Given this list of marker genes GBP1, S1PR2, P2RY1, NCOA7, IFITM2, DLGAP5, H2BC11, RSAD2, JUP, RASAL2, IFIT1 (NCBI Gene Id 8374), H2AC6, IFIT2, MEIS1, KDM7A-DT, CCR1, CCL20, CMTR1, KIAA1958 (KIAA1958), TCEAL7, ERICH3, AXL, ZCCHC2, IFI44, ISG15, PARP9, SLC7A13, SPATS2L, IL1RN, TNFAIP6, JAK2, RIN2, MARCKS, ZBP1, EPSTI1 (NCBI Gene Id 94240), ACP2, BCL2L14, MSLN, IFITM1, SHISA5, HERC6, HERC5, CYP2J2, KCTD14, TOR1B, RTP4, MIR3945HG, CCL2, CXCL11, IFI6, OLR1, HELZ2, LINC00189, CDC45, ATRIP, APOBEC3A, CCL8, LY6E, CYP4F11, OTOF, ABCF1, NRIP1, TMC1, SIGLEC1, RNF213, STX1B, H2AC13, GLYATL2, VTA1, OAS1, IL4I1, SAMD4A, CTSL, GMPPB, UBE2L6, ADAR, PLSCR1, KIAA0408, CLIC6, LAMP3, H2AC17, LINC02347, NAGS, SPC25, RGL1, KLHDC7B, H3C10, FRMD3 (FERM domain containing 3), NMI, MX2, C1orf116, POU1F1, CD38, IFIT3, IFI44L, OAS2, TRIM69, KITLG, EIF2B2, LAP3, ATP10A, PI4K2B, ANKRD22, H2AC15, SLFN5, SP110, PNPT1, NT5C3A, TDRD7, RNF213-AS1, GCH1, HGD (homogentisate 1,2-dioxygenase), IFIT5, CHMP5, IFI27, FANCL, RIGI, TRIM22, C2orf88, ZNFX1, KIF2C, TNF, OASL, LINC00470, GMPR, DTL (NCBI Gene Id 51514), LINC00293, EIF2AK2, STAT1, CHRND, SUCNR1, WARS1, SNTB1, REC8, APOL6, DDX60L, HESX1, KIF23, GPR84, ABTB2, NEXN (NCBI Gene Id 91624), PHF11, USP18, BLVRA, CYP4Z1, PLAC8, LGALS3BP, TRIM25, PARP12 (poly(ADP-ribose) polymerase family member 12), IRF7, IFITM3, RTCB, SAMD9, TMEM132D-AS1, CMPK2, LINC00880, FHL2 (NCBI Gene Id 2274), FPR2, POLE2, BRCA2, SLC1A1, DDX60, OAS3, SERPING1, HMMR, H2BC21, FFAR2, SAMD9L, C3AR1, GADD45B, CXCL10, ZNF853, IFIH1, CCL4, PRPS1, LINC00487, TMEM107, DEPDC1B, PARP14, STOM, SPINK13, TNFSF10, MRPS18C, SPOCD1, DTX3L, MX1, CCR5, TAP1, GALNTL5, TYMS, TNFRSF1A, IFI16, XAF1, SMOX, MVB12A, SLC12A8, DHX58, PBK, here is a description of the gene set: species: Homo sapiens The immune responses generated by YF-17D by profiling genes in 25 vaccine recipients were accessed at days 1, 3, 7, and 21 post-vaccination compared to pre-vaccination in PBMCs. The immune responses generated by YF-17D by profiling genes in 25 vaccine recipients were accessed at days 1, 3, 7, and 21 post-vaccination compared to pre-vaccination in PBMCs. Genes down-regulated in comparison of unstimulated peripheral blood mononuclear cells (PBMC) 3 days after stimulation with YF17D vaccine versus PBMC 7 days after the stimulation. Human Gene Set: GSE13485_DAY3_VS_DAY7_YF17D_VACCINE_PBMC_DN from publication Querec TD, Akondy RS, Lee EK, Cao W, Nakaya HI, Teuwen D, Pirani A, Gernert K, Deng J, Marzolf B, Kennedy K, Wu H, Bennouna S, Oluoch H, Miller J, Vencio RZ, Mulligan M, Aderem A, Ahmed R, Pulendran B (PMID 19029902)